Given this list of marker genes Ccn1, Gdf5, Fgf4, Fgf2, Rara, here is a description of the gene set: species: Mus musculus Mouse Gene Set: GOBP_CHONDROBLAST_DIFFERENTIATION The process in which a mesenchymal cell, acquires specialized structural and/or functional features of a chondroblast. Differentiation includes the processes involved in commitment of a cell to a chondroblast fate. A chondroblast is a precursor cell to chondrocytes.